The following is a description of a gene set: part of: Mitotic G1 phase and G1/S transition studied in species Homo sapiens Reactome Pathway: G0 and Early G1 In G0 and early G1 in quiescent cells, p130 (RBL2) bound to E2F4 or E2F5 and either DP1 or DP2, associates with the MuvB complex, forming an evolutionarily conserved DREAM complex, that represses transcription of cell cycle genes. During early G1 phase in actively cycling cells, p107 (RBL1) forms a complex with E2F4 and DP1 or DP2 and represses transcription of E2F target genes. Both p130 (RBL2) and p107 (RBL1) repress transcription of E2F targets through recruiting histone deacetylase HDAC1, possibly in complex with other chromatin modifying enzymes, to E2F-regulated promoters. Expression of p107 (RBL1) is cell cycle regulated, with its levels peaking in late G1 and S phase. Although p107 (RBL1) is phosphorylated by cyclin D assocaited kinases during late G1 phase, a small pool of p107 (RBL1) is thought to be present throughout G1 and S phase, and could be involved in fine tuning the transcription of S-phase genes. This is supported by studies showing that unlike RB1 and p130 (RBL2), which are able to induce G1 arrest when over-expressed, p107 (RBL1) over-expression can arrest the cell cycle in both G1 and S phase. For recent reviews on the function of p107, p130 and pocket proteins in general, please refer to Wirt and Sage, 2010, MacPherson 2008 and Cobrinik 2005., and this is the list of marker genes: TFDP1, CDC6, MYC, CCNA1, PCNA, LIN9, LIN52, RBL1, E2F4, CDC25A, CCNA2, MAX, CDK1, CDK2, CCNE1, RBBP4, E2F1, TFDP2, TOP2A, MYBL2, E2F5, RBL2, DYRK1A, CCNE2, HDAC1, LIN37, LIN54